The following is a description of a gene set: A developmental process, independent of morphogenetic (shape) change, that is required for an anatomical structure to attain its fully functional state. Mouse Gene Set: GOBP_ANATOMICAL_STRUCTURE_MATURATION species: Mus musculus, and this is the list of marker genes: Baiap3, Nrxn1, G6pdx, Nfasc, Arcn1, Tdrkh, Pth, Ppard, Tal1, Trim58, Pebp1, Cacna1a, Hoxa5 (NCBI Gene Id 15402, homeobox A5), Cx3cr1, Washc1, Ccl21a, Mecp2, Wnt1, Aldh1a2, Hba-x, Adamts12 (NCBI Gene Id 239337), Rec8, Fbxo5, Ythdf2, Slc22a14, Axl, Tdrd1, Ebp, Rac3 (Rac family small GTPase 3), Cebpa, Tdrd5, Tdrd7, Btk, Il15, Catsper4, Calca, Sox18, Lrrk2, Hes1, Brd1, Nom1, Fat4, G6pd2, Plxnb1, Fam210b, Runx3, Pld6, Gm36723, Brca2, Pgr, Gm15915, Bcl2, Zbtb16, Ankrd17, Zar1, Zbtb7a, Fam20c, Tdrd6, Pparg, Fgfr3, Abhd2, Rnase9, Insl3, Wnt5a, Catsperz, Tmprss12, Cntn2, Tmem79, Ltf, Iqcf1, Ereg, Anks1, Bap1, Defb1, Rb1, Svs3b, Fzd5, Akt1, Spink1, Ghrhr, Klf1, Cbfb, Cdkn1a, Bloodlinc, Vegfa, Snx10, Ercc2, Pou2f2, Diaph3, Ank3, Kcnq2, Svs3a, Slc26a6, Grb14, Spinkl, Gja1, Catsperb, Gata2, Nrcam, Notch1, Catsper3, Epo, Tyms, Myo5a, Ccl19, Cdkn1c, Ext1, Pde3a, Bfsp1, Smim45, Pdgfb, Ptk2b, Ren1, Kctd9, Gnaq, Cdh3, Actl6b, Catspere2, Epas1, Galnt3, Psen2, Tssk3, Nsun2, Mir133b, Nemp1, Ropn1, Bnc1, Gdf11, Tcp11x2, Adgrb3, Srrm4 (serine/arginine repetitive matrix 4), Runx2, Snx19, Klf2, Lsm14b, Cabyr, H3f3a, Hdac6, Kcnq3, Clec7a, C3, Hoxb13 (NCBI Gene Id 15408), Rxfp2, Sclt1, Gata3, Bmp2, Kcnip2, Myoc, Tgfb2, Ankle1, Hes5, Krtap21-1, Hif1a, Mbtps2, Ednra, Gpat4, Msx2, Rflnb, Id2 (NCBI Gene Id 97802), Bcl11a, Fermt1, Efcab9, Abl2, Prkaca, Septin4, Trpc4ap, Npr2, Ift80, Catsper2, Actn3 (actinin alpha 3), Kdr, Ccdc39, Foxa1, B4galt6, App, Pcsk4, Gsdma3, Plcb1, Nox1, Mir212, Ntn4, Tusc2, Esr2, Grem1, Semg1, Sox10, Bsph1, Rac2, Xbp1, Cftr, Sema4d, Zar1l, Mreg (melanoregulin), Sptbn4 (spectrin beta, non-erythrocytic 4), Ptgs2, Pabpc1l, Pmp22, Epha8, Tcp11, Six3, Wdr77 (WD repeat domain 77), Lgi4, Pla2g10, Dleu2, Sox8, Trip13, Rac1, Ccnb1, Enpp1, Bsph2, Tbx6, Reck, Ryr1, Epb42, C1ql1, Rflna, Lep, Cdc25b, Vsx1, Spg21, Foxo3, Kcne1, Gsk3b, Nr4a2, Irx5, Slc26a3, Tmigd1, Gba1, Scarf1, Rfx3, Asxl2, Dmc1, S1pr1, Lyl1, Adamts7, Wnt10b (wingless-type MMTV integration site family, member 10B), Igf1, Tfcp2l1, Akr1b1, Cspg4, Kif14, Pth1r, Flvcr1, Fgfr1, C1qa, Fbxo41, Ctnnb1, Nfix, Syt4, Tut4, Rhoa, Fem1b, Oosp2, Thbs3, Phospho1, Gal, Sirt2, Kdm1a, Catsperd, Mir132, Foxj1, Lhx6, Farp2, Runx1, Grip2, Ret, Kcnb1, Cend1, Slfn14, Tut7, Mtor (mechanistic target of rapamycin kinase), Dchs1, Heatr3, Shb, Cntnap2, Cst5, Trpv1, Pla2g3, Fev, Cdk5r2, Hid1, Ngf, Ihh, Grin1, Akap5, Ednrb, Mos, Opa1, Ropn1l, Map3k13 (mitogen-activated protein kinase kinase kinase 13), Neurog2, Aurka, Rnd1, Angptl8, Washc5, B4galt5, Maea, Kcnma1, Dld, Bfsp2, Defb37, Dsg4, Ctsl, Cdk5r1, Dag1, Rbpj, Ascl1, Adam7, Barx2, Ccdc154, Ppp2r1a (protein phosphatase 2, regulatory subunit A, alpha), L3mbtl3, Rps6ka2, Slc24a4, Dlg2, Dazl, Rere, Wee2, Gldn, Psen1, Mmp2, Ier3ip1, Il21, Lcn6, Pax2, Cdh5, Ano6, Nppc, Atp6ap2, Catspere1, Xylt1, Ccr6, Edn1, Ddit3, Bhlha15, Nf1, Tgfb1, C2cd6, Ptbp3